Given this list of marker genes Rtl5, Fam124a, Ralgapa1, Arel1 (apoptosis resistant E3 ubiquitin protein ligase 1), Stard13, Trdn, Tmem41b, Hs3st4, Golm1, Rbm20, Agpat5, Gpatch11, Arrb1, Gpr162 (G protein-coupled receptor 162), Cyp2g1, Imp4, Meis2, Clstn1, Lgr5, Stmn4, Cd180, Scarb2, Map3k13, Six6, Vapa, Kcnb2, Lhx2, Ybx1, Gale, Il12b, Tubgcp3, Rbmx2, Arhgap6, Mecp2, Sfrp1, Gpr83, Nabp1, St8sia2, Sfswap, Btbd8, Cacna1e, Fen1, Gpx8, Fbxl20, Mturn (NCBI Gene Id 68235), 1810055G02Rik, Samd10, Gas2l3, Uba6, Swt1, Fam20c, Itk, Slc23a2, Rad9a, Arl4a (NCBI Gene Id 11861), Lsm1, Pkdcc (protein kinase domain containing, cytoplasmic), here is a description of the gene set: Mouse Gene Set: MIR_133B_5P studied in species Mus musculus Genes predicted to be targets of miRBase v22 microRNA mmu_miR_133b_5p in miRDB v6.0 with MirTarget v4 prediction scores > 80 (high confidence targets). from publication Chen Y, Wang X (PMID 31504780)